Given this list of marker genes TLE1, CD37, LEF1, PPP3CA, CBX8, UQCRFS1, HILPDA, GPATCH2L, TWNK, CCR7, ARL4C, HM13, OST4, FBXL3, PIK3IP1, PTPN9, SQSTM1, NBR1, TSC22D3, STARD5, ARPC4, CDKL1, SERTAD4, PRCC (proline rich mitotic checkpoint control factor), PCGF5, NARF, SMAD3, NCOA7, TP53, RHOA, EIF1B, RGS3, GAK, GM2A, KLHL42, GKAP1, ITGAE (integrin subunit alpha E), LYRM4, PSME3, CAPG, GALNT6, CAB39, B4GALNT1, FBL, SLC25A51, FRG1, PFN1, TTC5, QRICH1, ELOVL5, LENG8, TRMT44, DUSP10, PPP1R18, RNF167, GNGT2, CAPN10, PPP4R3A, ZNF169, SLC35C1 (solute carrier family 35 member C1), ZNF146, PAK1, ARF3, SAFB, ETF1, PSMB5, EIF2AK3, ELF2, MIEF2, ADORA2A, ST6GAL1, JUNB, AMPD1, STK35, UGCG, DDX21, ASH2L (NCBI Gene Id 9070), AMZ1, ZBTB21, SLC37A3, ELF4, CTXN1, AP2B1, BAHCC1, PAFAH1B1, LRRC41, SLAIN1, KIF13A, SLC9A9 (solute carrier family 9 member A9), GPR171, ZNF827, AIM2, CHST11, HNRNPU, SLC25A17, RCC2, PRKCH, EMC4, ZDHHC9, UTP15, DECR2 (NCBI Gene Id 57382), SIDT1, TMEM38A, ADIPOR1, NTN1, DUSP22, MOCS3, CDKAL1, ELK4, IFNGR2, GRB2, VANGL2, TGIF1, HMGB1, TRAF6, DNAJB11, RAD23B, CECR2, C1orf21, ACAA1 (NCBI Gene Id 30), EIF4A1, ZC3H14, MGAT2, PSAP, SS18, CMPK1, SPRING1, PLAA, PARP3, TMEM248, NAA40, MEF2D, CRYBG1, E2F4, NPR2, TOX, PCGF1, CCL25, ITFG2, STK25, PRCP, BPNT1, RBMS2, FAAH, NOTCH3, ARSJ, ATXN7L3, ZDHHC5, RAB12, LAMC1, CYTH1, PDZD11, HIPK1, TMEM106C, NCSTN, TMEM39B, KLK8, GTF2H3, TCEAL1, MAPK6, GNB1, IL12RB1, PABPC4, CD9, PNLDC1, IFNGR1, EEIG1, MYB, SLC31A2, TP53RK, CTPS2, BCL9 (NCBI Gene Id 607), LIG3, PLEKHN1 (NCBI Gene Id 84069), DSTN, OTUB1 (OTU deubiquitinase, ubiquitin aldehyde binding 1), RASSF2, DGKQ, ASS1, SRSF9, DDOST, CCDC43, EXOC6B, UNKL, CDK13, CSDE1, SIGMAR1, ARFIP2, NDRG3, METRN, LMNB1, SAR1A, CCDC71, PRAMEF8, TSPAN31, ALDH18A1, CARD6, UBE2Z, LSM2, TM4SF20, here is a description of the gene set: from publication Szanto A, Balint BL, Nagy ZS, Barta E, Dezso B, Pap A, Szeles L, Poliska S, Oros M, Evans RM, Barak Y, Schwabe J, Nagy L (PMID 21093321) Human Gene Set: GSE16385_MONOCYTE_VS_12H_ROSIGLITAZONE_IL4_TREATED_MACROPHAGE_DN Human CD14 positive monocytes were purified from healthy volunteers’ blood and cultured in vitro for 4, 12, 24, 72 hours. While culturing, macrophages were activated alternatively with interleukin-4 (IL-4 100 ng/ml) or classically with interferon-gamma (IFNg 100 ng/ml)+tumor necrosis factor (TNF 50 ng/ml) or left without activation. Simultaneously, macrophages were also treated with vehicle (DMSO:ethanol) or 1mM synthetic PPARg agonist, Rosiglitazone. We used Affymetrix microarrays (U133Plus 2.0) to analyze activation and PPARg-induced gene expression changes. Genes down-regulated in monocytes (12h) versus macrophages (12h) treated with IL4 and rosiglitazone. species: Homo sapiens